Given this list of marker genes AFMID, HAAO, FAH, GSTZ1, PAH, TDO2, HPD, KYNU, IL4I1, HGD, IDO2, TAT (NCBI Gene Id 6898), IDO1, ACMSD, QDPR, KMO, here is a description of the gene set: Human Gene Set: GOBP_ERYTHROSE_4_PHOSPHATE_PHOSPHOENOLPYRUVATE_FAMILY_AMINO_ACID_CATABOLIC_PROCESS The chemical reactions and pathways resulting in the breakdown of erythrose 4-phosphate/phosphoenolpyruvate family amino acid. species: Homo sapiens